Given this list of marker genes CPLX1, GPX4, COL9A2, LETM1, NSD2, SALL1, PCNT, BGN (NCBI Gene Id 633), POR, BPNT2, PRKAR1A, COL9A1, NPR3, RPS6KA3, CTBP1, FGFRL1, IHH, COG4, COL9A3, PDE4D, here is a description of the gene set: studied in species Homo sapiens Abnormal metacarpal epiphysis morphology Human Gene Set: HP_ABNORMAL_METACARPAL_EPIPHYSIS_MORPHOLOGY